Given this list of marker genes IL1RL1, PLPP1, NRP1, TSPAN7, FCN3, BTNL9, MEG3 (maternally expressed 3), TMEM204, SLC14A1, IGFBP5, EHD3, ARHGDIB, TGFBR2, SLC44A1, PLAT, KDR, GMFG, PRX, MGP, LGALS3BP, COL4A1 (NCBI Gene Id 1282), S100A4, ARGLU1-DT, FLT1, ADGRF5, LDB2, ID2, RBMS1, PLPP3, NOSTRIN, CEBPB, FGL2, EMCN, CMTM8, ARRDC2, TBX3, F8, HECW2, SOST (NCBI Gene Id 8149), EFNB1, SGK1, NTN4, GJA5, AQP1, ITGA8, POMP, ESM1, IL13RA2, SYNE1 (NCBI Gene Id 85448, spectrin repeat containing nuclear envelope protein 1), CRHBP, here is a description of the gene set: In this study, an extensive analysis was conducted to define meta-programs (MPs) capturing intra-tumor heterogeneity across a spectrum of tumor types. The approach utilized non-negative matrix factorization (NMF) to analyze each cell type separately within individual tumor samples. This involved the analysis of malignant cells, macrophages, fibroblasts, endothelial cells, epithelial cells, T-cells, and B-cells. NMF was executed with varying parameter values (K=4, 5, 6, 7, 8, 9), thereby generating 39 programs for each cell type per sample. Each NMF program was summarized by the top genes based on NMF coefficients.\nRobust MPs were then delineated for each cell type using a set of stringent criteria, including recurrence within the same tumor, similarity to programs in other tumors, and non-redundancy within a tumor. Subsequently, these robust NMF programs were clustered (per cell type) based on Jaccard similarity, leading to the identification of MPs associated with each cell type.\nTo enhance the quality of the MPs, a refinement steps were undertaken, involving the removal of MPs suspected of reflecting low-quality data (with an overrepresentation of ribosomal proteins or mitochondrial-encoded genes), single-study inclusion, or similarity to miss-annotated cell types. Genes upregulated in subsets of cells of a given type within various tumors species: Homo sapiens from publication Gavish A, Tyler M, Greenwald AC, Hoefflin R, Simkin D, Tschernichovsky R, Galili Darnell N, Somech E, Barbolin C, Antman T, Kovarsky D, Barrett T, Gonzalez Castro LN, Halder D, Chanoch-Myers R, Laffy J, Mints M, Wider A, Tal R, Spitzer A, Hara T, Raitses-Gurevich M, Stossel C, Golan T, Tirosh A, Suvà ML, Puram SV, Tirosh I (PMID 37258682) Human Gene Set: GAVISH_3CA_METAPROGRAM_ENDOTHELIAL_ENDO_4